Given this list of marker genes BBS5, HS6ST1 (NCBI Gene Id 9394), TAL1, ENG, SALL1, ALX3, SOX18, STIL, TBX15, HOXD11, IGF2, IFT140, PLK4, ZEB1, FOXC2 (forkhead box C2), FLT3LG, PCGF2, NEUROD1 (neuronal differentiation 1), SLC44A4, E2F8, BMP4, EGLN1, TPRN, HOXD10, KRT8, RDH10, ZNF568, GJB6, RAD23B, TEAD4 (TEA domain transcription factor 4), SLC39A3, CCDC103, HYAL1, NSDHL, WNT2, MYC, OTX1, ANKRD24, CSF2 (colony stimulating factor 2), RBP4, ATP6V1B1, HOXA2, INSIG1, FZD3, LEF1, FZD6, RPL10, MYO15A, HOXB2, HOXB6, MAFB, CLRN1, RBPJ, NR4A3, PKD2, DLX5, WNT9B, E2F7, WDPCP, YAP1, EPAS1, EPHA2, FUZ, WNT1, MKKS, PDGFB, PPP1R13L, APELA, PPIL1, INSIG2, TCF21, MAP2K1, TH, BMP5, PRKRA, ATOH1, HSD17B7, FGFR2, NKX2-6, FOXL2, CLRN2, FGF10, ASB2, DCANP1, LBX1, TBX20, ACVR1, PRICKLE1, WDR48, RARA, VASH2, SPRY2, FOXN4, BPTF, TRIM28, PSEN1, BMI1, CDX4, NEUROG1, NOG, ITGA8, CRB2, KDR, GRXCR1, HOXB7, HOXB8, TFEB, FRZB, TTPA, PAX8, HOXB5, SETDB2, ATF4, NAGLU, HEY1, SMAD2, EN2, MFSD2A, HOXC9, HOXD3, SCRIB, UTP25, NCOA1, HEY2, PHACTR4, VANGL2, ZFPM2, ASCL2, PKDCC, MYB, CDH23, KCNQ1, GJA5, HESX1, IRX5, TRIOBP, MYO7A, TULP3, EN1, IL3, ARID2, CC2D2A, GBX2 (NCBI Gene Id 2637), ZIC3 (Zic family member 3), SH2B3, STOX1, DLG1, GLI3, NOTO, MESP1, PDGFA, HMX2, SMO, TECTA, HOXA3, NECTIN1, POU4F3, NES, MTHFD1, NKX2-5, PLS1, SOX15, STK4 (serine/threonine kinase 4), PBX3, CDX2, EPN1 (NCBI Gene Id 29924), RUNX2, PAX2, APLNR, POLE, RBBP6, PBX4, WNT7B, HOXA5, SHOX2, HOXA11, DNAJB6 (NCBI Gene Id 9186), IFT172, CHD7, TGFBR2, HSCB, RBPMS2, NDST1, CEP290, STK3, GRHL3, SOBP, C2CD3, PCDH12, FBN2, RNF207, PTK7, HOXA7, TBX4, HOXC4, COL11A1, TEAD3, EGFR (NCBI Gene Id 1956), OSR2, EFNA1, SPINT1, HES1, ARL13B, MBD2, CHRNA9, SIX2, JUNB, TMED2, FOXI1, WNT5A, EPHB2, FOXH1, MIB1, TPO, EIF4A3, SIX4, DSCAML1, FOXG1, STRC, GSC, KITLG (NCBI Gene Id 780897), SEC24B (NCBI Gene Id 10427), MTHFD1L, FRS2, PCDHA10, FOXF2, PROX1, DVL2, MYF5, HIPK2 (NCBI Gene Id 653052), MYO6, RYR2, NCKAP1, PALB2, HOXD4 (homeobox D4), RPL38, MEF2C, HNF1B, CCDC134, USH1G, KIT, IFT122, GATA2, SIX3, VPS52, MSX1, PAX5, TWIST1, ARNT, ALX4, NIPBL, PPP1R35, CCDC39, AKT1, CCDC40, TTC39C, HIF1A, FOXC1, TP53, GRB2, MKS1 (MKS transition zone complex subunit 1), STRA6, VASH1, IFT57, DLL1 (NCBI Gene Id 28514), SHH, TAF10 (NCBI Gene Id 6881), KMT2A, HOXD9, ZFPM1, HOXC11, SIX1, COL2A1, IHH, FGF9, HOXA1, GGNBP2, WNT11, LLGL2, FOXF1, ALX1, CCN1, CRYAA, PLG, TBC1D23, KCNQ4, SPINT2, PDGFRA, MEGF8, MAPK3, TGFB2, GREB1L, HMX3, NDRG4, PHLDA2, SOD1, MAPK1, TFAP2A, EDNRA, LHFPL5 (LHFPL tetraspan subfamily member 5), MMP14, WNT3A, ESRRB, WHRN, EYA1, HPN, NHERF1, SYF2, CHRNA10, ZIC1, TBX2, TRAF3IP1, TCAP, GRXCR2, ATP8A2, EOMES, GDF3, GATA4, TBX18 (T-box transcription factor 18), GLI2, SENP2, FZD5, NOTCH2 (NCBI Gene Id 55574), GJB5, CEBPA, USH1C, EDN1, CITED2, MFAP5, SOCS3, PLCD3, SUFU, SMAD3, SCT, PBX1, RSPO3, FGFR1, CEBPB, CDK20, ERCC3, NECTIN3, COBL, LRIG1, THOC5, SLC39A1, DLX6, CITED1, FOLR1, FBN1, PRRX1, PTCH1, GLI1, ADM, NR2F2, CLUAP1, BMPR1A, REST, TEAD2, MICAL2, GRHL2, ALDH1A3, CXCL8, SPARC, SOX11, PAX6 (paired box 6), FOXE1, GATA3, PITX2, VAX2, MBD3, PKD1, SLITRK6, OTOP1, IFT52, HOXB3, TGFB1, LHX1, FZD2, ERCC2, KDM2B, MFAP2, TTBK2, TBX3, PDZD7, DYNC2I1, SP3, DLX2, OSR1, SRF, TRA2B, SNAI1, ELF5, AHI1, HOXB9, TMIE, TEAD1, CDKN1C, EFEMP1, ALDH1A2, BBS7, RARG, ID3, NODAL, LIF, MED12, FGF8, BLOC1S5, NPHP3, RAC1, CIMAP3, CTHRC1, CDC42, HLX, TGFBR1, NKX3-2, RARB, BIRC6, MYO3A, ADA, NTN1, ZFP36L1, PCSK5, PBX2, SATB2, HSF1, FBXW8, CASP8, VEGFA, HIPK1, HOXB1 (homeobox B1), IL10 (NCBI Gene Id 3586), DVL1, BMP7, BCR (BCR activator of RhoGEF and GTPase), SOX9, CHST11, DNAAF1 (dynein axonemal assembly factor 1), SOX17, FLVCR1, OVOL2, ST14, ID2, MYO3B, HOXA4, POU3F4, TBX1 (NCBI Gene Id 7413), TUBB2B, KRT19, GATA1, TIFAB, MYCN, NOTCH1, HAND2, WNT16, TNF (NCBI Gene Id 7124), GDNF, TSHZ1, RARRES2, MDFI, PLXNA4, GCM1, WDR19, LRIG3, RNF112, PRDM1, MMP16, HOXB4, CTNNB1 (NCBI Gene Id 1499), MED1, CDC40, ECE1, HAND1, HOXA9, here is a description of the gene set: Human Gene Set: GOBP_EMBRYONIC_ORGAN_DEVELOPMENT species: Homo sapiens Development, taking place during the embryonic phase, of a tissue or tissues that work together to perform a specific function or functions. Development pertains to the process whose specific outcome is the progression of a structure over time, from its formation to the mature structure. Organs are commonly observed as visibly distinct structures, but may also exist as loosely associated clusters of cells that work together to perform a specific function or functions.